The following is a description of a gene set: studied in species Mus musculus from publication Chen Y, Wang X (PMID 31504780) Mouse Gene Set: MIR_875_3P Genes predicted to be targets of miRBase v22 microRNA mmu_miR_875_3p in miRDB v6.0 with MirTarget v4 prediction scores > 80 (high confidence targets)., and this is the list of marker genes: Sgpl1, Sdhd, Cacul1, Ptpn21, Fam81a, Tmem8b, Rabgap1l, St6gal1, Klc2, Cwc27, Arhgap29, Sema3e, Lyrm1, Mmut, Psd3, Lrch2, Dcc, Hccs, Sspn, Ppig, Thrb, Ikzf2, Arl8b, Med14, Map9, Slc30a4, Spast, Resf1, Mcidas (multiciliate differentiation and DNA synthesis associated cell cycle protein), Nom1 (nucleolar protein with MIF4G domain 1), Zdhhc21, Ebf3, Lancl3, 9330159F19Rik, Sema5a, Chrdl1, Mical2, Pik3cg, Sema3a, Dnajc10, Nadk, Tfap2c, Rxra, Gak (NCBI Gene Id 231580), Zfp507, Zfp39, Pds5b, Nab1, Golgb1, Nell2, Trps1, Mid2, Rab1a, Sbf2, Gabbr1, Hacd2, Mybl1, Onecut2, Inpp4b, Ralgps2, Bnc2, Fzd3, Stambpl1, Zmat3, Arid4a, Ect2, Tnrc6c, Naaladl2, Tspan2, Dcx, Vcpip1, Ubxn7, Mapk9, Zfp148, Agap1, Gria3, Zfp111, Zfp398, Or52n4, Ccdc85a, Sgip1, Snx1, Mapk8 (NCBI Gene Id 26419), Klf12, Hycc2, Myl12a, Ttpa, Adamtsl3, Top1, G3bp1, Dcun1d4, Psmd12, Hnrnpa0, Elp4, Cpeb3, Hesx1, Cnot6 (CCR4-NOT transcription complex, subunit 6), Ralgps1, Cdyl2, Frk, Stxbp6 (syntaxin binding protein 6 (amisyn)), Chrd, Braf, Mex3c, Foxd1, Wdr1, Atrx, Qser1, Thoc2, Fut9, Med1 (NCBI Gene Id 19014), Rheb, Sestd1, Eloc, Car8, Zmynd11, Kras, Bicd1, Slk, Reck, Taf7, Spin2c, Gab3, Pou3f3, Mmd, Tra2b, Tmem132b, Tmed10, Dlg1, Eny2, Mier1, Ssx2ip, Smg1, Cnr1, Tmem107, Paxbp1, Rhoq, Sumo1, Rb1cc1, Arl15, Rprd1a, Vcan, Rab3c, Dzip3, Cldn12, Rnf138, S2bpcox16, Ssr1, Dido1, Itga6, Carnmt1, Ywhae, Scai, Epha5, Mapk1ip1l, Hoatz, Sumf1, Kcnc2, Zmym6, Metap2, Dcstamp, Stag2, Fat3, Aak1, Ptbp3, Pkig, Prex2, Grin1os, Slc25a31, Cep170, Ostc, Kpna4, Rapgef4, Rtf1, Aebp2, Ash1l, Nlgn1, Tardbp, Gng2, Msrb3, Kbtbd8, Edar, Pam, Taf4, Ipo8, Zfp639, Atxn7, Hook3, Map3k2, N4bp2l2, Nubpl, Washc4, Bcl10, Npr3 (NCBI Gene Id 97975), Cetn4, Rasa1, Rwdd1, Dpp4, Rbm24, Slitrk1, Nhlh2, Rfx3, Mef2c, Rnft1, Tmem59, Pde5a, Thsd7a, Acvr1, Nr2c2, Tbc1d12, Asah1, Adam12, Prkag2, Exoc5, Chd9, Ddx46, Trak2, Zbtb44, 4921524J17Rik, Sgms2, Oat, Ids, Ptprb, Ppm1g, Rnd1, Atp11c, Asxl3, Appbp2, Tgfa (NCBI Gene Id 21802), Nr3c1, Adam22, Ranbp17, Kif5b, Csmd2, Mbtd1, Mgat4a, Cert1, Ptprj, Zdhhc20, Ret, Phip, Spag16, Wnk3, Hgf, Zwilch, Serbp1, Nqo2, Plxdc2, Adamts19, Elf1, Pdha2, Edc3, Dcun1d5, Ubxn2b, Tmco3, Pias1, Zbtb7c, Tmed7, Crebrf, Kalrn, Gja5, Atp8a1, Rimbp2, Dnmt3a, Ptchd1, Pou3f1, Akap13, Ythdf2, Rsf1 (NCBI Gene Id 77334), Bmpr2, Eif2ak3, Zfp827, Adamts5 (ADAM metallopeptidase with thrombospondin type 1 motif 5), Taf1b, Micu3, Chd5, Ppm1b, Abhd13, Carf, Srgap1, Ino80d, Cdh2, Prrt4, Ddx3x, Larp4b, Nkain2 (NCBI Gene Id 76197), Cggbp1, Bbs5 (Bardet-Biedl syndrome 5), Zfp971 (zinc finger protein 971), Mixl1, Psma3, Bmpr1a, Srp54a, Usp32, Rab33b, Tigd4, Zfp966, Lmo3, Klhl24, Cox16, G6pc2, Tmem41b, Ttc39b, Spred1, Crebzf, Dpy19l3 (dpy-19 like C-mannosyltransferase 3), Naip1, Elavl1, Tnfsf10, Papolg (poly(A) polymerase gamma), Pak2, Yod1, Arhgap6, Ppp1r9a, Dennd10, Slco1a6, Cebpzos, Cstb, Atm, Vma21, Rab8b (RAB8B, member RAS oncogene family), Men1, Moxd1 (NCBI Gene Id 74332), Rubcnl, Csmd3, Mss51, Sec14l1 (NCBI Gene Id 74136), Sav1, Esyt2, Pm20d2, Trhde, Fuca2, Arfgef2, Sfxn4, Glcci1, Igsf9b (immunoglobulin superfamily, member 9B), Golm2, Vsig1, Socs7, Cd44, Mindy3, Nfat5, Gucy1a2, Zfp652, Unc5d, Bend3, Grm1, Pex3, Septin8, Mbd4, Yes1, Hlf, Ppp4r2, Ercc4, Fem1c, Ubr2, Rnf41, Pcm1, Usf3, Lrp8, Rbms3, Gdpd1 (NCBI Gene Id 66569), Pcdh7, Golga4, Cpeb2, Pde1c, Bbx, Pou4f2, Itm2c, Dgkb, Irag1, Zfp967, Plekha8, Slc6a1, Creb5, Trim36, Ski, Btbd18, Ammecr1, Actn1, Agpat5, Phlda1, Col19a1, Rundc3b, Kctd12, Kctd1, F11, Rabep1, Eml5, Rarres1, Kdm7a, Tmem184b, Cyp7a1